The following is a description of a gene set: species: Homo sapiens Genes in the cancer module 485. Human Gene Set: MODULE_485, and this is the list of marker genes: MSX2, CDC6, ARHGEF16, CAP2, COL10A1, CELF4, DENND3, PCLAF, ELF3, SSH1, RFC4, SCG3, MYBL2, KRT20, NQO1, SSUH2, IPPK, GSDMB (gasdermin B), ARL2, GRIK2, GPN2, DLGAP5, RBM42, HOOK1, PLIN2, FCHO1, PCNA (NCBI Gene Id 5111), UBE2S, STX6, GPR160, NT5DC2, SYT4, BUB1, GLT8D2, TINCR, MAP1A, RRM2, CD24, AURKA, BDH1, ZNF777, MCF2L2, POLE (NCBI Gene Id 80252), CCNA2, PDK2, SLC40A1, ACYP2, FADS2, S100P, SNRPB, GPC5, UNG